The following is a description of a gene set: Human Gene Set: GOBP_FC_RECEPTOR_MEDIATED_STIMULATORY_SIGNALING_PATHWAY The series of molecular signals generated as a consequence of a the binding of the Fc portion of an immunoglobulin by an Fc receptor capable of activating or perpetuating an immune response. The Fc portion of an immunoglobulin is its C-terminal constant region. species: Homo sapiens, and this is the list of marker genes: PAK1, FGR, APPL2, PLA2G6, VAV1, PTPRC, FYN, NR4A3, LYN, PTPRJ, PRKCE, CD47, PTK2 (protein tyrosine kinase 2), CD226, RABGEF1, FCER2, VAV3, LIMK1, MYO1G, SRC, PLPP4, VAV2, ABL1, SYK, PLD2, NOS2, IFNG, RAP1A (NCBI Gene Id 5906), CSK, PRKCD, APPL1 (NCBI Gene Id 26060), FCER1G, PLSCR1, YES1, HCK